The following is a description of a gene set: species: Homo sapiens Human Gene Set: REACTOME_OPIOID_SIGNALLING Opioid Signalling, and this is the list of marker genes: GNG13, PPP2CA, GNG2, GNAT3, GNG12, MAPK1, GNAL, PPP3CA, PPP2CB, GNAI2, CREB1, GNAI3, ITPR3, PPP1R1B, PRKACB, GNA15, PPP2R1B, GNA14, PDYN, PRKCG, GNAQ, ADCY6, CDK5, PLCB2, PPP3R1, PLCB4, PLA2G4A, PDE4A, PLCB3, CAMKK1, CAMKK2, ITPR2, GNB4, ITPR1, PRKAR2A, PLCB1, GNB3, PDE4B, PDE4D, ADCY8, GNG3, CAMK2A, CAMK2G, ADCY2, GNGT1, PRKAR1B, GNGT2 (NCBI Gene Id 2793), NBEA, PDE1C, GNG5, ADCY4, ADCY7, PPP3CC, CALM1, PPP1CA, GNB5, GNG7 (NCBI Gene Id 90274), CAMK4 (NCBI Gene Id 814), ADCY1, PPP2R1A, GNG11, GRK2, PRKX, KPNA2 (karyopherin subunit alpha 2), PRKCD, PRKACA, PDE1A, GNG8, POMC, PRKACG, PRKCA, ADCY5, OPRM1, ADCY3, GNA11, CAMK2D, GNG10, CAMK2B, GNAI1, GNB2, GNG4, PDE1B, PRKAR2B, PPP2R5D, PRKAR1A, PDE4C, AHCYL1, GNB1, ADCY9, PPP3CB